The following is a description of a gene set: The series of molecular signals initiated by the binding of a double-stranded DNA or RNA from another organism to cytosolic cyclic GMP-AMP (cGAMP) synthase (cGAS) that activates innate immune responses through production of the second messenger cGAMP, which activates the adaptor STING. Human Gene Set: GOBP_CGAS_STING_SIGNALING_PATHWAY species: Homo sapiens, and this is the list of marker genes: DDX41, PPP6C, TREX1, SMPDL3A, PRKDC, BANF1, PCBP2, MARCHF5, MAP3K7, SLC19A1, RNF39, ZDHHC9, TAB1, SPSB3, MIR4691, TBK1, LYPLAL1, IRGM (NCBI Gene Id 345611), AKT1, BTK, CGAS, PARP1 (NCBI Gene Id 142), AARS2, AURKB, IRF3, STING1, ZDHHC18